Given this list of marker genes Hmga1, Spi1, Kras, Smc5, Plk2, Calr, Arg2, H2ax, Gch1, Eef1e1, Terf2, Fbxo4, Pla2r1, Rbl1, Pot1b, Mirlet7f-2, Twist1, Pml, Bcl2l12, Trp53, Zfp277, Mif, Ypel3, Smc6, Vash1, Brca2, Nuak1, Mirlet7g, Mirlet7f-1, Icmt, Cdkn2b, Zmpste24, Zmiz1, Zkscan3, Nup62, Tert, Fbxo5, Npm1, Bmpr1a, Pnpt1, H2-M3, Prkdc, Gins3, Ybx1, Bcl6, Hras, Id2, Wrn, Fzr1, Morc3, Srf, Suv39h1, Bmal1, Mnt, Prkcd, Prelp, Mirlet7d, Cav1, Tbx3, Ilk, Dnaja3, Opa1, Pten, Cited2, Abl1, Wnt16, Nsmce2, Map2k1, Pawr, Cgas, Trp63, Cdkn2a, H2aj, Nek4, Mtor, Hmga1b, Nampt, Sirt6 (NCBI Gene Id 72769), Mapkapk5, Mapk14, Tbx2 (NCBI Gene Id 21385), Top2b, Ecrg4, Map3k3, Htt, Cdkn1a, Akt3, Zfp217, Hmga2, Comp, Wnt1, Kat6a, B2m, Ndufs6, Rsl1d1, Sirt1 (sirtuin 1), Abi3 (ABI family member 3), Lmna, Ang, Prmt6, Cdk6, here is a description of the gene set: Mouse Gene Set: GOBP_CELLULAR_SENESCENCE A cell aging process stimulated in response to cellular stress, whereby normal cells lose the ability to divide through irreversible cell cycle arrest. studied in species Mus musculus